Given this list of marker genes Polm, Dnm3, Cops2, Ptbp3, Nek9, Tyw5, Npc1, Macir, Zfand5, Jag1, Cenpv, Dpysl2, Dis3l2 (NCBI Gene Id 77551), Lpp, Dhx16, Dap3, Sftpa1, Npas3, Lrrc1, Xcl1, Zfp248, Cdk6, Rhbdl3, Ppp1r10, Abhd3, Pde7a, Dpf2, Nsdhl, Hmgb2, Btf3, Desi2, Kif21b, Hrh1, Fbxo41, Tbc1d14, Rgs8, Nrp2, Btg1, Hoxa4, Ubxn8, 9930111J21Rik1, Htr1f, Numa1, Kat6a, Apol7c, Lyz2, Cgref1 (NCBI Gene Id 68567), Ccnj, Man2a1, Sdf4, Rinl, Hlx, Pbx2, Mlc1, Senp7, Meis1, Wipf3, Gucy2g, Prpf39, Gemin2, Slc8a1, Lama1, Cpne7, Man1b1, Lrrc73, Pik3r6, Stx2, Edc3, Necap1, Bub3, Arhgef7, Ntf5, Fgf4, Apol7a, Rap1a, Prcc, Wdcp, Gpr174, Dnajb3, here is a description of the gene set: species: Mus musculus from publication Chen Y, Wang X (PMID 31504780) Genes predicted to be targets of miRBase v22 microRNA mmu_miR_6998_3p in miRDB v6.0 with MirTarget v4 prediction scores > 80 (high confidence targets). Mouse Gene Set: MIR_6998_3P